Given this list of marker genes ID2, IFI27, TNFSF9 (TNF superfamily member 9), CXCL3, IL6, EFNA1, CXCL2, POLR2J, CXCL8, here is a description of the gene set: from publication Simbulan-Rosenthal CM, Trabosh V, Velarde A, Chou FP, Daher A, Tenzin F, Tokino T, Rosenthal DS (PMID 16007217) Solar ultraviolet B (UVB) acts as both an initiator and promoter in models of multistage skin carcinogenesis. We found that, whereas UVB induces apoptosis in human papillomavirus-16 E6/7-immortalized keratinocytes, it inhibits markers of differentiation in human foreskin keratinocytes (HFK). Potential mechanisms for this differential response were examined by DNA microarray, which revealed that UVB alters the expression of three of the four human inhibitor of differentiation/DNA binding (Id) proteins that comprise a class of helix-loop-helix family of transcription factors involved in proliferation, differentiation, apoptosis, and carcinogenesis. These results were verified by RT-PCR and immunoblot analysis of control and UVB-irradiated primary and immortalized keratinocytes. Whereas Id1 was downregulated in both cell types, Id2 expression was upregulated in primary HFK, but not immortalized cells. In contrast, Id3 expression was significantly increased only in immortalized cells. The differential expression pattern of Id2 in response to UVB was recapitulated in reporter constructs containing the 5' regulatory regions of this gene. Id2 promoter activity increased in response to UVB in HFK, but not in immortalized cells. To identify the regulatory elements in the Id2 promoter that mediate transcriptional activation by UVB in HFK, promoter deletion/mutation analysis was performed. Deletion analysis revealed that transactivation involves a 166 bp region immediately upstream to the Id2 transcriptional start site and is independent of c-Myc. The consensus E twenty-six (ETS) binding site at -120 appears to mediate UVB transcriptional activation of Id2 because point mutations at this site completely abrogated this response. Chromatin immunoprecipitation and electrophoretic mobility-shift assays verified that the Id2 promoter interacts with known Id2 promoter (ETS) binding factors Erg1/2 and Fli1, but not with c-Myc; and this interaction is enhanced after UVB exposure. Similar to the effects of UVB exposure, ectopic expression of Id2 protein in primary HFK resulted in inhibition of differentiation, as shown by decreased levels of the terminal differentiation marker keratin K1 and inhibition of involucrin crosslinking. Reduction of Id2 expression by small interfering RNAs attenuated the UVB-induced inhibition of differentiation in these cells. These results suggest that UVB-induced inhibition of differentiation of primary HFK is at least, in part, due to the upregulation of Id2, and that upregulation of Id2 by UVB might predispose keratinocytes to carcinogenesis by preventing their normal differentiation program. species: Homo sapiens Human Gene Set: SIMBULAN_UV_RESPONSE_NORMAL_UP Genes up-regulated in HFK cells (primary keratinocytes) in response to UVB irradiation.